Given this list of marker genes Plcd3, Plekhm1, 9930022D16Rik, Gm16342, Gm11620, Wipi1, Ccdc43, Kif18b, Cep95, Nmt1, E030025P04Rik, Mir7223 (microRNA 7223), Kansl1, Rprml, Or51q1b-ps1, Arhgap27os2, Milr1 (mast cell immunoglobulin like receptor 1), Rps12-ps26, Ern1, Mettl2, 2410004I01Rik, Hexim2, Gm11715, Mdk-ps1, Dcaf7, Gm20511, Smurf2, Abca8a, Cyb561, Lyzl6, Gm9910, Sppl2c, Mapt, Map3k3, Gm11658, Gh, Gm39397, Gna13, Gm22683, Abca8b, Gm25337, Arf2, Gm11624 (NCBI Gene Id 276809), Nsf, Limd2, Marchf10, Ddx5, 1700028N14Rik, Axin2, Polg2, Cacng5, Gm11652, Taco1, Dcakd, Scn4a, Ace, Smarcd2, 1700096J18Rik, Gm11643, Itgb3, 2810433D01Rik, Gm11667, Cd79b, Meioc, Gm11650, Gm11716, Cacng4, Tanc2, Psmc5, C1ql1, Tlk2 (tousled-like kinase 2 (Arabidopsis)), Hexim1, Map3k14, Gm11718, Wnt3, Cep112, Fam20a, Gm11621, Fam187a, Abca6, Gpatch8, Gm11662, Apoh (NCBI Gene Id 11818), Psmb5-ps (NCBI Gene Id 19174), 1700023C21Rik, Ace3, 1810010H24Rik, Psmd12, Cep112it, Fzd2, Gm11627, Kcnh6, Helz, Map2k6, Gm25362, Mir6931, Slc16a6, Mir3064, Prr29, Gm11638, Eftud2, Tcam1, Gm22378, Higd1b, Arsg, A830035A12Rik, Adam11, Cep112os1, Lrrc37, Cacng1, Mir6932, Arhgap27os1, Wnt9b, Gm11653, Nol11, Gm11661, Fmnl1, Pecam1, Icam2, Abca5, Gm11696, Bptf, Gfap, Acbd4, Gosr2, Snord104, Efcab3, Prkar1a, Efcab15, Ftsj3, Lrrc37a, Crhr1, Gm22711, Gm11655, Gm11713, Strada, Prkca, Ddx42, Amz2, Gm11663, Abca9, Arhgap27, Kpna2, Gm11622, C130046K22Rik, Gm11714, Taco1os, Tex2, Gm10840, Gm8738, 1700052K11Rik, Gm11685, Gm11708 (predicted gene 11708), Gm22743, Gjc1, Spata32, Gm11651, Gm11623, 1700012B07Rik, Ccdc103, Gm11683, Pitpnc1, Myl4, Gm11637, Mrc2, Rgs9, Cdc27, Arhgap27os3, Ccdc47, Gm11657, Gm23645 (predicted gene, 23645), Gm11665, here is a description of the gene set: studied in species Mus musculus Mouse Gene Set: chr11E1